Given this list of marker genes SIN3A, COL11A2, GGT7, KPNA6, MEF2D, GLYCTK, ACAD11, MKS1, KRT2, SEC24A, DENND4A, COQ10A, KRT85, WDR5, SPPL2B, RTBDN, COPS7A, GFM2, S100PBP, VPS53, CNPPD1, RRP9, URGCP, TADA2B, PRKD2, SEMA4F, SMG5, DBNL, COMMD2, CASP2, RMND5B, TUT1, TEX261, DHX37, AP2A1, STAT5B, ITIH1, THRAP3, SCAMP2, GIGYF1, ADD2, DDX11, USP6 (NCBI Gene Id 9109), DNAJC4, here is a description of the gene set: Neighborhood of DDX11 DEAD/H (Asp-Glu-Ala-Asp/His) box polypeptide 11 (CHL1-like helicase homolog, S. cerevisiae) in the GCM expression compendium Human Gene Set: GCM_DDX11 species: Homo sapiens Neighborhood of DDX11